Given this list of marker genes Acvr2a, Acvr1c, Inhbb, Inhba, Mapk3, Smad3, Fstl3, here is a description of the gene set: part of: Signaling by TGFB family members This event has been computationally inferred from an event that has been demonstrated in another species.<p>The inference is based on the homology mapping from PANTHER. Briefly, reactions for which all involved PhysicalEntities (in input, output and catalyst) have a mapped orthologue/paralogue (for complexes at least 75% of components must have a mapping) are inferred to the other species. Reactome Pathway: Signaling by Activin electronically inferred by orthology from the curated human pathway species: Mus musculus